Given this list of marker genes NF2, NF1, MLH1, MSH6, SPRED1, here is a description of the gene set: studied in species Homo sapiens Human Gene Set: HP_AXILLARY_FRECKLING The presence in the axillary region (armpit) of an increased number of freckles, small circular spots on the skin that are darker than the surrounding skin because of deposits of melanin. Axillary freckling